The following is a description of a gene set: Dolichyl-phosphate mannosyltransferase (DPM), a heterotrimeric protein embedded in the endoplasmic reticulum membrane, mediates the transfer of mannose (from cytosolic GDP-mannose) to dolichyl phosphate (DOLP) to form dolichyl-phosphate-mannose (DOLPman). The first subunit of the heterotrimer (DPM1) appears to be the actual catalyst, and the other two subunits (DPM2 and 3) appear to stabilise it. Defects in DPM2 can cause congenital disorder of glycosylation 1u (DPM2-CDG, CDG1u; MIM:615042), a multisystem disorder caused by a defect in glycoprotein biosynthesis and characterised by under-glycosylated serum glycoproteins. CDG type 1 diseases result in a wide variety of clinical features, such as defects in the nervous system development, psychomotor retardation, dysmorphic features, hypotonia, coagulation disorders, and immunodeficiency. part of: Diseases associated with glycosylation precursor biosynthesis species: Homo sapiens Reactome Pathway: Defective DPM2 causes DPM2-CDG, and this is the list of marker genes: DPM1, DPM2, DPM3